Given this list of marker genes IL4, COQ9, MFN2, IDH1, NDUFA8, SDHB, NDUFS3, NDUFB2, COQ10A, COX8C, NDUFA10, MACROH2A1, CISD1, AIFM2, IL10RB, ETFA, NDUFV1, MT-CO3, COX6B1, NDUFB11, MDH1, NDUFS1, NDUFA3, TRAP1, ENSG00000293600, CHCHD2, UQCRB, SIRT3, NDUFS2, NOS2, UQCRFS1P1, MLDHR, COX6A2, MT-ND4L, UCN, SUCLA2, MSH2, COX7B2, COX7A1, NDUFB5, NDUFS5, MDH1B, NDUFA4, UQCRH, NDUFA2, ATP5IF1, PPIF, TRPV4, NDUFAF1, C2orf69, OXA1L, PLEC, ABCC9, UQCR11, NUPR1 (NCBI Gene Id 26471), IDE, IMMP2L, SLC25A23, FXN, NDUFB1, FH, MDH2, MT-ND5 (NCBI Gene Id 4540), ATP5PB, PARK7, PRDM16, COX4I1, TEFM, OGDHL, ATP5F1A, CS (citrate synthase), COL6A1, NDUFB4, AK4, ETFRF1, OAS1, ATP5F1C, NDUFA12, NDUFA7, DNAJC30, ATP5PO, VCP, SLC25A25, TREX1 (three prime repair exonuclease 1), ADSL, TMEM135, DLAT, UQCRHL, COX7A2P2, CHCHD5, MT-ND3, NDUFA5, UQCC2, BID, ACO2, ATP5F1EP2, PDHA1, DGUOK, NDUFA6 (NADH:ubiquinone oxidoreductase subunit A6), SHMT2, NDUFA13, ARL2, KGD4, COX7C, SNCA, NOP53, CYP1A2, CCNB1, HCCS, OPN3, ACO1, NDUFB6, COX5B, ATP5F1B, RHOA, ABCD1, NDUFB10, IFNG, PUM2, NDUFB3, CDK1, PANK2 (NCBI Gene Id 80025), COX7B, CYC1, NDUFB9, SDHAF4, IDH2, NDUFS8, MT-CO2, ACTN3, NDUFB8, COX4I2, MTFR2, MYBBP1A, SCO2, MT-ND6, COX6B2, DNAJC15, COX6C, CHCHD10, IDH3B, NIPSNAP2, DLST, CSKMT, MTFR1, NDUFA11, COX7A2, COX8A, MT-ND2, ATP5MG, NR4A3, ATP5ME (ATP synthase membrane subunit e), BCL2L13, MFSD8 (NCBI Gene Id 256471), SDHD, MTLN, NFATC4, NDUFS7, COX6A1, COA6, VPS54, MTCO2P12, LYRM7 (LYR motif containing 7), NDUFS4 (NCBI Gene Id 4724), ATP5F1E, ME3, MLXIPL, IFNAR1, MT-CYB, CAT, PPARGC1A, IDH3A, SDHA, NDUFC1, SDHC, MTFR1L, UQCR10, NDP, NDUFS6, COX10, NDUFA1, MT-ATP8, UQCRC2, MT-CO1, NDUFC2-KCTD14, ATP7A, NDUFB7, ATPSCKMT, STOML2, PDHB, COX7A2L, NNT, SUCLG2, MT-ND1, COQ10B, PIK3CA, MT-ATP6, BLOC1S1, MTCH2, ATP5MF, ATP5F1D, SDHAF2, SURF1, TNF, UQCRC1, NDUFC2, GHITM, ETFB, DLD, ATP5PD (NCBI Gene Id 519), PINK1, PNPT1, ISCU, PDHA2, UQCC3, SOD2, SLC25A51, UQCRFS1, SLC25A13, CYCS, CBFA2T3, ETFDH, NDUFV2, GBA1, ATP5PF, IFNLR1, SLC25A33, NDUFV3, UQCRQ, ANTKMT, MIR210, MT-ND4, NDUFAB1, NDUFA9, IDH3G, PRELID1, SUCLG1, SLC25A14, COX5A, OGDH, here is a description of the gene set: Human Gene Set: GOBP_CELLULAR_RESPIRATION The enzymatic release of energy from inorganic and organic compounds (especially carbohydrates and fats) which either requires oxygen (aerobic respiration) or does not (anaerobic respiration). studied in species Homo sapiens